Given this list of marker genes CACNG4, ADAM11, LGI1, STX1A, ADAM22, LGI4, CACNG2, LGI2, DLG4, STX1B, CACNG8, LGI3, CACNG3, ADAM23, here is a description of the gene set: studied in species Homo sapiens LGI-ADAM interactions Human Gene Set: REACTOME_LGI_ADAM_INTERACTIONS